The following is a description of a gene set: Any process that modulates the frequency, rate or extent of phosphatidylcholine metabolic process. Human Gene Set: GOBP_REGULATION_OF_PHOSPHATIDYLCHOLINE_METABOLIC_PROCESS species: Homo sapiens, and this is the list of marker genes: APOC1, MFSD2A (NCBI Gene Id 84879), FABP3, LPCAT1, LDLR (low density lipoprotein receptor), ACSL3, SCARB1, ABCA3, RAB38, CAPN2